The following is a description of a gene set: Binding to a patched (ptc) protein, a receptor for hedgehog proteins. species: Homo sapiens Human Gene Set: GOMF_PATCHED_BINDING, and this is the list of marker genes: SHH (NCBI Gene Id 6469), IHH, SMO, DHH, PTCH1, CAV1, BBS1, CCNB1